Given this list of marker genes TBX18, ISL1, BVES, TBX3, SHOX2, here is a description of the gene set: Human Gene Set: GOBP_SINOATRIAL_NODE_CELL_DEVELOPMENT The process whose specific outcome is the progression of a sinoatrial (SA) node cell over time, from its formation to the mature state. SA node cells are pacemaker cells that are found in the sinoatrial node. species: Homo sapiens